Given this list of marker genes Mesp1, Tbx5, Tbx3, Bves, Isl1, Gata6, Popdc2, Shox2, Tbx18, here is a description of the gene set: studied in species Mus musculus Mouse Gene Set: GOBP_SINOATRIAL_NODE_DEVELOPMENT The process whose specific outcome is the progression of the sinoatrial (SA) node over time, from its formation to the mature structure. The SA node is part of the cardiac conduction system that controls the timing of heart muscle contraction. It relays electrical signals to the AV node.